Given this list of marker genes PTK2, GRB7, EFNA5, MAPK3, SRC, PIK3CA, MAP4K4, NCK1, EPHB3, RASA1, MAP2K1, ITSN1, EFNB3, PIK3R1, RAC1, NRAS, GRB2, EFNB2 (NCBI Gene Id 1948), EPHB1, RAP1A, KRAS, MAPK1, ROCK1, EPHB2, PAK1, CDC42, HRAS, WASL, SYNJ1, TF, EPHB4, CRK, SHC1 (NCBI Gene Id 6464), EFNB1, KALRN, RRAS, GRIA1, PXN, DNM1, RAP1B, here is a description of the gene set: studied in species Homo sapiens from publication Schaefer CF, Anthony K, Krupa S, Buchoff J, Day M, Hannay T, Buetow KH (PMID 18832364) EPHB forward signaling Human Gene Set: PID_EPHB_FWD_PATHWAY